The following is a description of a gene set: This pathway describes resistance of ERBB2 KD mutants to tyrosine kinase inhibitor tesevatinib. Reactome Pathway: Resistance of ERBB2 KD mutants to tesevatinib species: Homo sapiens part of: Drug resistance in ERBB2 KD mutants, and this is the list of marker genes: ERBB2, ERBIN, CDC37, HSP90AA1